Given this list of marker genes Snai2, Rxra, Cyp27b1 (NCBI Gene Id 216437), Pdia3, Kdm6a (NCBI Gene Id 22289), Mn1, Phex, Fgf23, Med1, Tnc, Cyp24a1, Rxrb, Sfrp1, Trim24, Fes, Vdr, Penk, Kank2, Gdap1, Snw1, Casr, Gprin3, Pim1, here is a description of the gene set: species: Mus musculus Any process that results in a change in state or activity of a cell (in terms of movement, secretion, enzyme production, gene expression, etc.) as a result of a vitamin D stimulus. Mouse Gene Set: GOBP_CELLULAR_RESPONSE_TO_VITAMIN_D